Given this list of marker genes FAM43A, GLO1, HCST, PIKFYVE, POGLUT3, PICALM, PCGF2, SAMD4B, ITK, TRIM17, PMS1, CAP1, FRMD8, PRCC, MLEC, LETMD1, LIPC, INTS12 (NCBI Gene Id 57117), RBPJ, PAICS, SCFD2, SETD7, BIN3, ABHD1, PPEF2, CCN2, ST13, USP8, RANBP10, MTMR1, RABGAP1L, SCARB2, ETV3, ALG9, CENPI, CLIP1, POLR3B, CROT, SETDB1, NCAPD3, KCNA3, PPP1CB, KIF2C, CERS2, FYB1, TPST2, TGOLN2, S100A6, SYTL2, GGNBP2, ELL, NCOA3, REL, H4C16, METAP1, FBRS (NCBI Gene Id 8734), ORC5, H2AC4, SMG7, CRYGS, SLC20A1, LSM10, RCL1, RGS1, DSG2, CBLN3, RHBDD3, GADD45B, PRDX1, TTC41P, METTL13, LPXN, TRAPPC5, GCK, SSBP4, METTL5, PRPF40A, TMEM164, MYL4, ENTPD5, RSPRY1, CNTD1, NUP153, FAM98B, MLH1, CILK1 (NCBI Gene Id 51541), ZNF426, CATSPER2, STX7, HSF4, CREB1 (cAMP responsive element binding protein 1), KCTD20, H3C11, CBX7, CCL1, POU2AF1, HSPA4L, COA3, CHD1L (NCBI Gene Id 9557), PPIE, H1-5, TRAF3IP3, FYN, RNF11, ZBTB1 (zinc finger and BTB domain containing 1), SGK1, SLC25A24, CD28, ARHGEF6, NUMA1, HOOK2, PIMREG, APAF1, CDK19 (cyclin dependent kinase 19), H2AC19, HP1BP3, WDR26, ZNF330, GGTA1, AGGF1 (angiogenic factor with G-patch and FHA domains 1), TXN, SLC25A40, EAF1, LRIF1, TNPO1, RAMP1, RAD54L2, DDIAS, PLLP, NR1D1, EML4, LYRM4, CEP120, SLC37A3, IKBIP, PTGER1, BMI1, GBP2, MINK1, ITGAL, H2AC8, CXCR5, SIL1, FEM1B, PBRM1, POP5, ADH1A (NCBI Gene Id 124), ADAM10, RAP1A, GRAP, CDK4, PER1, RRP12, DDX39A, INTS13, CD3D, CFAP418, TCEAL9, TRIM44, CA12, USP48, ARL6IP5, CHIC2, FHIP1B, FARS2, TMEM167A, MTO1, MRPL34, CMTM7, CCNI, DCLRE1B, LRRC8D, RNF115, CTSD, H2BC5, ENOPH1, RAB19, ARHGAP11A, IL2, SLC25A33, SEMA4A, MFSD11, FASLG, ADGRE4P, CHMP4B (NCBI Gene Id 60501), ORM1, CD2, MFSD6, SLC3A2, FBXO48, SESN1, NFATC2, STAT6, DAP3, TEX19, ATP10D, SLC39A10, DNAJB4, MAD2L1BP, PSMB3, GAS5, TPGS2, CSK, RAB2A, OACYLP, MINDY3, ABCB8, CEP57L1, ZC3HAV1, CCDC117, NR1H3, PHAF1, PECAM1, MYNN, SRRM2, USP4, FOXJ3, CCR3, UBB, ANXA9, BIRC3, KDM5B, FAH, DYRK1A, MAP2K6, TCEANC2, HHAT, MAP3K5, MDM2, SNAI3, BLTP3B, CUL3, GTPBP2, APBA2, RHOA, GTPBP1, ITIH5, UBE2V1 (ubiquitin conjugating enzyme E2 V1), MLLT3, ACTRT3, SSBP3, ETF1, PIP5K1A, ELOA, GLCE, SYPL1, RETREG3, AMZ2, FGL2, TSNAXIP1, FLOT1, NRP1, SFR1, KHDC4, MYC, RNMT, GOLPH3L, CCR1, H4C8, MAP4K4, WDR59, TBK1, ING3, SMIM14, VPS37B, GSAP, BACH1, CNOT2, SEPTIN6, SLC25A45, TMEM19, POLG2, NPB, SRSF1, FGF7, URM1, ANAPC11, TNFRSF1B, ATM, XRCC4, ACOT2, ZBTB22 (NCBI Gene Id 9278), CUTALP, APLP2, YKT6, HERC4, LYRM1, CD274, MRPS28, KCTD10, CGA, FBXO9, KPNB1, GSTM2, PYHIN1, ECE1, PMPCA, PYM1, SPA17, CRYAB, CAMK1D, ADORA2A, POLR1E, SKIL, OSBPL8, ECPAS, MEFV, FAM135A, CDKN1B, BLOC1S6, PRRG4, NRIP1 (NCBI Gene Id 8204), KIAA1191, ELL3, PDIA3, AVPI1, PSMC2, TIAL1, HSPA13, CNOT6L, CLEC2D, UBE2W, SCNM1, TES, PPP4R1, IZUMO1R, SERINC1, TAF8, PLCD1, TOMM34, ZC3H12D (zinc finger CCCH-type containing 12D), MCM3, SRP54, ACTBL2, CSF1, SYNRG, ZFAND5, SARS1, NUP43, ZNF280D, SIPA1L1, GPR35, CGREF1, EEA1, PPT1, DARS2, MARCHF6 (membrane associated ring-CH-type finger 6), HERC1, TLE3 (TLE family member 3, transcriptional corepressor), SMG5, TFB2M, DCAF1, PTGER4, CCDC18, MINDY1, CMPK1, H2AC18, SAMSN1, TTLL12, ETS1, UTP6 (NCBI Gene Id 55813), PSMD4, SUSD6, ERN1, BLOC1S5, HADHA, CXCL10, MRPL45, THY1, MBNL1 (NCBI Gene Id 9850), FRMD6, ITM2B, H3C8, ATOSA, ATXN1, HSPBAP1, TMED5, DDB2, LYSET, MRPL33, NASP, EFL1, OAF, UBE2G2, MS4A6A, ARL5B, ZAP70, TBRG1 (NCBI Gene Id 84897), H2BC13, FKBP1A, ART2BP, RHEB, USP17L24, EPM2AIP1, NAP1L4, DCUN1D3, ARHGAP10, GPR146, P4HA3, CISH, DHFR, NRBP1, EOLA1, HOOK3, SNAPC3, BNIP2, HSD17B10, PDCD2 (programmed cell death 2), PNRC2, NBR1, ZBTB5, IRF2, CAD, UCP2, PARK7, GTF3C6, CPSF2, WSB2, TMEM50A, LST1 (leukocyte specific transcript 1), H3C13, PLG, TOM1L2, SGPP1, COG3, OSBPL9, H4C14, TGIF1, SLC26A8, KAT2B, RUBCN, SNRNP25, ANKMY2, GPD2, DCLRE1C, CBX3, TMEM30A, MAPKAPK3, CISD2, AASDHPPT, H2AC25 (NCBI Gene Id 92815), ABHD12, CTSC, WDR31, BBS4, HCLS1, RGS2, PFKM, PPP2R1A, CPD, CD72, MAPRE2, MEIG1 (NCBI Gene Id 649987), UBR1, DTL, SEPHS1, CGAS, HECTD2, REST, WDR6, CYLD, RPUSD2, HADHB, ARIH2, CFAP68, DAPP1, LNPEP, MCL1, MIX23, ADIPOQ, SRGN, RILPL1, ZPBP2, RSRP1, PAIP2, SIAE, INSIG1 (NCBI Gene Id 3638), SMAD7, PSME3IP1, UBE2R2, LRP10, ISCU, TAB2, CD3G, AFTPH, STK11IP, SLC25A15, COMMD3, DYNLT2, PLIN2, FAM133B, SENP1, CCR4, BCAR1, PDE6D (NCBI Gene Id 5147), CITED2, MRPS31, YTHDF3, JAML, HNRNPUL1, ITPRIP, ATP6V0A1, SLC36A1, MGME1, GPR18, NSFL1C, H3-4, GPR22, BLCAP, TCTA, SMARCC1, POU2F3, MRPL36, DDIT4 (DNA damage inducible transcript 4), LYSMD1, ACOT1, FAM185A, SART3, SLC9A9, NOP58, OCIAD2, NFIA, CRTAM, CLIC1, LYSMD3, TIMM21, CTDSPL2, ELOVL5, DENND4A, TTC24, SASH3, PCSK1, PLGRKT, GBP6, CEPT1, STK26, SNX30, TBL1XR1, ASPH, ROCK2, DNAI4, JUNB, NOCT, ME1, NABP1, ECT2, DNAJA2, CELA1, KLF6, TUBG1, NAT9, LRRC27, KCNN4, C1orf74, ADM, PDK1, NDUFS6, LIPH, XPA, P2RY10BP, GCNT3, UBA3, EVI2B, NDUFAF3, PTBP3, MAP3K1, ATP5PD (ATP synthase peripheral stalk subunit d), POLD4 (NCBI Gene Id 57804), LRRC25, LGALS8, WBP11, HNRNPDL, FHL2, UBL3, ATG9B, KDM2B, PRUNE1, CSNK1G2, KDM6A, F2RL2, ALYREF, SELENOI, TSHZ1, PTPRJ (protein tyrosine phosphatase receptor type J), TMEM209, NRGN, KDM5A, NUP210, PSMD5, ATP1A2, MRPL42, LY9, PEAK1, ORMDL1, NCKAP1, UBXN8, SAXO2, RTN3, BABAM2, TESK2, RIDA, AKIRIN2, TNIP3, DNAAF11, CENPL, DGKA, GRAP2, ZFP1, IER3, HNRNPA1L2, ARPC1B, RCC2, UBE2D1, NEDD9, PTPRC, RHOG, NCF1, RNF170, APH1A, CAB39, GLIPR1, FUBP1, HNRNPU, H2BC11, CCNG2, RBKS (ribokinase), TRPC4AP, TMEM167B, GYPC, FTH1, H2BC26, SLC2A1 (NCBI Gene Id 6513), COA7, SHISA5, LCP2, PTPN22, CCDC77, TNFRSF9 (TNF receptor superfamily member 9), ANGPTL4, CABP1, TNFSF4, ST8SIA4, NFATC3, MPHOSPH8, FIP1L1, CHEK1, KBTBD3, TOPBP1, JMJD6, ZNF281, PCMT1, CD3E, DNAJB12, ELAVL1, RAB8B, TBCE, CIP2A, GSTCD, RNF121, TTC5, UBAP2L (ubiquitin associated protein 2 like), REEP3, DIXDC1, SUGCT, SERF2, XBP1, GFPT1, ELK4, ZNF205, PRDX6, FGR, GMFG, DIPK1A, JOSD1, DUSP6, DYNC2I1, THEMIS, ERP27 (NCBI Gene Id 121506), ITGB7, H2AZ1, PRRC2A, CSRNP1, TNFRSF18, ADD1 (NCBI Gene Id 118), VAMP4, H4C6, ATG12, MPLKIP, TBL1X, PRAF2, STAP1, SDF2 (NCBI Gene Id 6388), HSP90B1, EYA2 (NCBI Gene Id 2139), PPP2R5A, SLC6A4, NFKBID, SLC23A2, GPAT4, FAM162A, LEO1, TRPC2, CAMK2G, TMEM134, MAPK6, KDM5C, IL2RA (interleukin 2 receptor subunit alpha), CDK17, UBALD2, CSTB, LRP2BP, SESN2, METTL6, SLC35B4, FLAD1, ATP5IF1, H1-3, WASF2, WRAP53, USP10, H4C3, WFS1, H3C14, ZFP3, CDYL2, ARL11, NDFIP1, DENND1B, C1GALT1, NFAT5, PPP1R13B, CTPS1, RGS3, SIX6, CFAP43, PRR13, FAM107B, SUPT6H, DBF4, PMVK, LY96 (lymphocyte antigen 96), FBXW12, IL10RA, TMEM62, SLFN12, LTB, NEK7, TIPARP, COBLL1, C12orf60, NT5E, SETD5, NARS2, MAT2B, PIM1, PPAT, ARG2, ABHD8, DNAJC8, SRPK2, SRSF3, RIOX2, STX16, ASH1L, TOLLIP, TMED2, CCPG1, UBXN4, ARIH1, DNAJB14, ARID1A, FAF1, DBR1, EVI2A, STAT3, PTGR3, SLC17A6, SMAP2, PLSCR1, ENTR1, CETN4P, HSPH1, THUMPD3, CD53, GIMAP5, RPS6KA5 (NCBI Gene Id 9252), SPATA6, DAP, UBE2N, HNRNPF, EGR2, EID1, P2RX4 (NCBI Gene Id 5025), KIF5B, EIF5, RBM6, EPC2, MTRF1L, TMEM60, ORAI2, NPTN, BBS12, M1AP, DMAC1, COQ10B, ARMC8, UBE3B, TNFRSF19, DUT, ZFAND6, TMEM79, DRAM2, ARHGAP12, BRMS1L, ARL10, CXCR6, COPS7B, CHD1, LRRC58, ARHGEF12, LCTL, AIPL1, H4C9 (NCBI Gene Id 8294), EFCAB2 (NCBI Gene Id 84288), APBB1IP, POFUT1, MARCHF9, LEPROTL1 (NCBI Gene Id 23484), EPB41L2, SLC25A12, PGK1, SSMEM1, C16orf87, HMG20A, EIF4E, TRAT1, SYF2, POLR3C, AQP11, SLC49A4, TRIM5, CYTIP, TNFSF14, ERI2, SLC11A2, EAPP, TMEM53, SPRED2, XPO1 (exportin 1), SLC22A3, MSH5, FBXW10, MIER1, POLD3, HERPUD2, GOT2, ZNRF2, ASF1A, AQP9, RPS26, CCDC32, USP6NL, SNRNP35, MFSD14A (major facilitator superfamily domain containing 14A), KANSL2, UTP25, ERMARD, KPNA3, GLYAT, ACP2, ABHD13, VN1R5, EPCIP, NDUFV2, IFNK, ANXA7, TOR1AIP2, CCND3, JAK2, WDR45, CDC27, ALG8, BZW2, IRF8, RAB3GAP1, TP53, TMEM71, AKIRIN1, ZDHHC9, ZBED5, FAM72A, NRDC, IL9R, EIF4ENIF1, BCL10, VPS26C (VPS26 endosomal protein sorting factor C), CSTPP1, GSR, VTCN1, SDCBP, SUN2, SNAPC4, LYPLA2, ZWINT, GOLPH3, FYTTD1 (NCBI Gene Id 84248), ARHGDIB, SAMD13, CD47, P2RY10 (NCBI Gene Id 27334), SH2B3, AP4B1, ERCC1, ANTXR2, LETM2, XPNPEP3, GPR65, AHCYL1, GPR171, ZBTB25, UBE2D3, KTI12, SRPK1, FAM216A, DNASE1, BRCA1, ARID5B, DPYSL2, TRADD, KHNYN, SYNJ2, SCP2, TMPRSS4, H2AC20, KIFC1, VPS72, FCGR3A, DNAJC2, EDEM1, SYNE3, OS9, RBL2, SUPT20H, TMOD3, GSTT2, LIX1 (limb and CNS expressed 1), MSH3, PDCD1 (NCBI Gene Id 56179), SLC41A1, C1orf43, H4C4, GLT8D2, LCORL, CX3CR1, CENPA, H3C15, IDH1, H4C1, RCHY1, TCP11L2, GNG2, WDR44 (WD repeat domain 44), DDA1, PRMT5, LIMD2, IRAG2, ARL6IP6, AGO2, ACSL4, DLEC1, CYP1A1, PHTF2, RIOK2, SHC1, NUP58, TMED10, ABHD2, BSPRY, SLC5A6, NPC1, TMEM59, DHRS9, NPAT, NSUN6, LRR1, H3C1, GPN3, USP3, TLCD2, ATL3 (NCBI Gene Id 283241), ARMC6, GATB, OAZ1, SRXN1, IGSF8, GTF2A2, DZIP3, CDC40, PSEN1, ZBTB37, CENPC, ZFP36L1, RPS29, MDM1, S100A5, GABPB1, OGT, FRG2B, USF1, TRIM16, SLC35F6, DYNLT4, SARAF, SPAG9, RBL1, TOR1AIP1, here is a description of the gene set: species: Mus musculus Genes with promoters bound by FOXP3 in hybridoma cells stimulated by PMA and ionomycin. Human Gene Set: MARSON_BOUND_BY_FOXP3_STIMULATED from publication Marson A, Kretschmer K, Frampton GM, Jacobsen ES, Polansky JK, MacIsaac KD, Levine SS, Fraenkel E, von Boehmer H, Young RA (PMID 17237765) Foxp3+CD4+CD25+ regulatory T (T(reg)) cells are essential for the prevention of autoimmunity. T(reg) cells have an attenuated cytokine response to T-cell receptor stimulation, and can suppress the proliferation and effector function of neighbouring T cells. The forkhead transcription factor Foxp3 (forkhead box P3) is selectively expressed in T(reg) cells, is required for T(reg) development and function, and is sufficient to induce a T(reg) phenotype in conventional CD4+CD25- T cells. Mutations in Foxp3 cause severe, multi-organ autoimmunity in both human and mouse. FOXP3 can cooperate in a DNA-binding complex with NFAT (nuclear factor of activated T cells) to regulate the transcription of several known target genes. However, the global set of genes regulated directly by Foxp3 is not known and consequently, how this transcription factor controls the gene expression programme for T(reg) function is not understood. Here we identify Foxp3 target genes and report that many of these are key modulators of T-cell activation and function. Remarkably, the predominant, although not exclusive, effect of Foxp3 occupancy is to suppress the activation of target genes on T-cell stimulation. Foxp3 suppression of its targets appears to be crucial for the normal function of T(reg) cells, because overactive variants of some target genes are known to be associated with autoimmune disease.